The following is a description of a gene set: species: Homo sapiens Human Gene Set: GOBP_NEGATIVE_REGULATION_OF_LIPID_LOCALIZATION Any process that stops, prevents or reduces the frequency, rate or extent of lipid localization., and this is the list of marker genes: NR1H2, MIR148A, APOE, PLA2R1, MAPK3, ABCA1, MIR206, IL6, CRP, MIR33A, SREBF2, ADIPOQ, APOC1, IRS2, CRY2, PTPN2, CYP4F2 (NCBI Gene Id 8529), MIR27B, NR1H3, TREM2, MIR27A, MIR26A1, PPARD, MIR301B, MIR30C1, SHH, MIR17 (NCBI Gene Id 406952), TNF, MIR130B, PLA2G10, ITGB3, PNPLA2, TSPO, LEP, MIR144, AKT2, MIR758, PPARG, FIS1, MIR9-1 (NCBI Gene Id 407046), CLSTN3, AKT1, TTC39B, THBS1, APOC2, KCNK9, PTPN11, ABCA2, MIR33B, MIR613, MIR145, APOA2, MIR128-1, NFKBIA, ABCG1, MIR19B1, MIR93, MIR185 (microRNA 185), PCSK9, ABHD5, ACSL4, EGF, ITGAV, PPARA, CRY1, MIR146A, APOC3, MIR302A, CES1